Given this list of marker genes TNFSF4 (TNF superfamily member 4), HAVCR2, IL4R, XCL1, JAK3, IL33, LGALS9, IL1RL1, ASCL2, here is a description of the gene set: Any process that stops, prevents, or reduces the frequency, rate, or extent of a T-helper 1 type immune response. species: Homo sapiens Human Gene Set: GOBP_NEGATIVE_REGULATION_OF_T_HELPER_1_TYPE_IMMUNE_RESPONSE